The following is a description of a gene set: Genes down-regulated in monocyte-derived dendritic cells: LPS versus vehicle. Human Gene Set: GSE4984_LPS_VS_VEHICLE_CTRL_TREATED_DC_DN species: Homo sapiens Human monocyte derived dendritic cells matured via galectin-1 or LPS. from publication Fulcher JA, Hashimi ST, Levroney EL, Pang M, Gurney KB, Baum LG, Lee B (PMID 16785517), and this is the list of marker genes: BMPR1A, TBX19, MYO1C, AOAH, RAB27A, PPP1R16B (NCBI Gene Id 26051), FYN, HNRNPLL, LINC00221, PICALM, CNKSR3, GAB3 (NCBI Gene Id 139716), MICAL3, AIM2, FLVCR2, SGCB, ARHGAP35, TBXAS1, EPS15, LPAR6, NBEAL2, EMB, H3C7, SLC6A6, PRC1 (NCBI Gene Id 9055), SMAD5, NFATC2, CD58, ECPAS, EFCAB14, GPR108, PPP2R5C, CD5, CCDC92, CD99, DGKH, GNAO1, PTPRM, NF1, IL12RB1, PLEKHA5, SLA, ATP1A3, SELENOS, RO60, CCDC112, ACVR2A, NEK6, WNK1, ZNF335, ERN1, AUTS2, ASAP1, GALM, TNFAIP3, DNAJC1, TMEM106C, PLPP5, GTDC1, ARHGAP31 (NCBI Gene Id 57514), OR52I1, GGA2, ABI3, C1RL, ST8SIA1, HECTD3, TBC1D2B, RNF166, MGAT2, CD82, RASAL3, ZBTB16, FAM53B, FAAH2, NCOA2, PHACTR2, STK39, CD40LG, ATP2B4, CEP128, MICAL2, RUNX1 (RUNX family transcription factor 1), NIBAN1, FBXW11, ATXN1 (NCBI Gene Id 7912), UBR2, SPSB1, SYT11, WEE1, SLFN11, SLCO4C1, CAMTA1, NLRP3, NCKAP1, SUFU, CARD17P, PLEKHG3, CNNM3, HLA-DPA1, NCAPH (non-SMC condensin I complex subunit H), LRIG1, GALNT3, TMEM39A, RAP1GAP2, TOX, TRERF1, ADAM9, BRD10, CHST11, BICD1, AKAP13, USP45, CPEB4, CFLAR, DCP1B, KIF1B, GRAMD4, ACTN4, COTL1, TNRC18, TNFRSF9, NCOA6, PRDM1, SLC39A7, BLTP1, TMX4, SLFN13, IQGAP1, WSB2, MAF, BAZ2B (NCBI Gene Id 29994), GLUL, PIEZO1, CORO1C, TPRG1, SYNE1, SLC30A7, SAV1, CDH1, BATF (NCBI Gene Id 10538), NR3C1, FAM89B, TCIRG1, CRIM1, MBOAT1, C1orf21, RB1, APOBEC3D, LLGL2, CCR4, OGDH, PTP4A2, EPCAM, PDE1B, IQGAP2, ARHGDIA, MSS51, SNX30, KATNAL1, RCBTB2 (RCC1 and BTB domain containing protein 2), SLC9A9, MIB1, NFAT5, CCR5, BROX, SLC1A4, RNF19A, RHOU, APOBEC3G, CYTH3, PRKCD, TTC39C, PLXND1, IL9R, KLRF1 (NCBI Gene Id 51348), CXCR6, BNIP1, TMBIM6, MECP2, HLA-DPB1, RHBDF2, SNRNP200, PLAAT4, PCBP4, PDZD11, PTPN13, TGFBR3, CNOT1, SH3TC1, MIR199A1, DENND3, MYO5A, UTS2, KIF1C (kinesin family member 1C), DCN, PPP2R1B, ALOX5AP, AGO4